The following is a description of a gene set: Human Gene Set: HP_PALMOPLANTAR_ERYTHEMA species: Homo sapiens Redness of the skin of the palm of the hand and the sole of the foot caused by hyperemia of the capillaries in the lower layers of the skin. Palmoplantar erythema, and this is the list of marker genes: GJA1, WNT10A, GJA8, GJA5, DSP